The following is a description of a gene set: species: Homo sapiens Human Gene Set: LAKE_ADULT_KIDNEY_C25_ENDOTHELIAL_CELLS_UNASSIGNED from publication Lake BB, Chen S, Hoshi M, Plongthongkum N, Salamon D, Knoten A, Vijayan A, Venkatesh R, Kim EH, Gao D, Gaut J, Zhang K, Jain S (PMID 31249312), and this is the list of marker genes: MMRN1, CAST, KMT2E, PPP3CA, ST6GALNAC3, PLCB4, DOCK5, ZFAND3, RALGAPA2, KALRN, SSH2 (slingshot protein phosphatase 2), TCF12, FBXL7, DOCK9, STOX2, FOXP1, SRPK2, PDE7B, TSHZ2 (NCBI Gene Id 7765), TMEM161B-DT, ASAP1, SEMA3A, ARL15, FCHSD2, TCF4, PPFIBP1, EPB41L4A, PROX1, TPM4, CPNE8, MYH9, TFPI, ZFHX3, EFNA5, LDB2, ZFC3H1, UTRN, FOXP2